The following is a description of a gene set: studied in species Mus musculus Genes predicted to be targets of miRBase v22 microRNA mmu_miR_7222_3p in miRDB v6.0 with MirTarget v4 prediction scores > 80 (high confidence targets). from publication Chen Y, Wang X (PMID 31504780) Mouse Gene Set: MIR_7222_3P, and this is the list of marker genes: Ube2w, Ak2, Gpr157, Rbm27, Atosa, Celf1, Capn10, Ptgr2, Vps26c, Mtmr4, Erp44, Mepe, Pwwp2b, Megf11, Pdcd1, Nyx, Srgap1, Itpr3, Lypla2, Tmem186, Hbq1b, Pdia6, Ptpn14 (protein tyrosine phosphatase, non-receptor type 14), Ifi208, Gimap8 (NCBI Gene Id 243374), Gorasp1, Tmc1, Eln, Mrpl57, Nrros, Cuedc2, Srl, Elavl2, Med13l, Galnt16, Snx33, Rfx4, Klhl7, Prickle2, Eps15l1, Tmem178, Smc1a, Cstf2, Cdk9, Zbtb9, Mief1, Ifit1, Twf1, Sgsh, Max, Aak1, Xylb (NCBI Gene Id 235676), Pou2af1, Ccna2, Klhl8, Relt, Nhsl2, Zcchc7, Kcne1, Ccr9, Zglp1, Mapk6, Basp1, Aldh4a1, Smtnl2, Cd300e, Ifngr2, Bicd2, Zfyve27, Erlin1, Ppp2r5b, Dach2, Trim8, Sgsm1, Rab8a, Mrm1, Arhgap24, Gsdmc, Pgm3, Ufd1, Tgfb3 (NCBI Gene Id 21809), Aar2, Thsd7a, Ptpn5, Lingo3, Tmem117, Chd9, Pan2, Arrb1, Angptl7, Nrf1, Paqr5, Kbtbd2, Copg1, Cfap68, Rtraf, Kcnk13, Pacs2, Sprr2b, Syt7, Slc6a17, Ppm1b, Lpar1, Nfasc, Jpt1, Cnot9, Rgs14, Slc9a8, Slc2a4, Corin, Aacs, Strbp, Tmod2, Brpf1, Cstdc2, Top3a, Snx21, Slc30a2, Paqr7, Onecut2, Arl2bp, Slc35e2, Bzw1, Gmeb1, Ube2q1, Zfp426, Hmgb1, Frrs1l